The following is a description of a gene set: The process that activates or increases the rate or extent of granule cell precursor proliferation. species: Homo sapiens Human Gene Set: GOBP_POSITIVE_REGULATION_OF_CEREBELLAR_GRANULE_CELL_PRECURSOR_PROLIFERATION, and this is the list of marker genes: SHH (NCBI Gene Id 6469), EGF, FGF2, GPR37L1, IGF1